The following is a description of a gene set: Human Gene Set: GOBP_REGULATION_OF_OSTEOCLAST_DEVELOPMENT species: Homo sapiens Any process that modulates the frequency, rate or extent of osteoclast development., and this is the list of marker genes: LTF, NOTCH2, TNFSF11, FBN1, LILRB1, TYROBP, FBXW7 (F-box and WD repeat domain containing 7), CLDN18, SIGLEC15 (sialic acid binding Ig like lectin 15), GPR68, SLC9B2